The following is a description of a gene set: Reactome Pathway: Activation of TRKA receptors part of: Signaling by NTRK1 (TRKA) Trk receptors can either be activated by neurotrophins or by two G-protein-coupled receptors (GPCRs) although the biological relevance of GPCRs remains to be shown. studied in species Homo sapiens, and this is the list of marker genes: NGF, ADORA2A (NCBI Gene Id 135), NTRK1, NTRK2, ADCYAP1R1, ADCYAP1